Given this list of marker genes Jun, Sat1, Tbc1d4, Trim7, Ftl1 (NCBI Gene Id 14325), Evi2a, Dek, Slamf7, Adam23, Laptm5, Cxcl16, Mxd1, Csf2rb, H2az1, Mycbp2, Ucp2, H2bc4, Hspa1b, Chka, Hspa1a, Eno3, Cbfa2t3, Haus8 (NCBI Gene Id 76478), Btg2, here is a description of the gene set: Cytokines mediate cell-cell communication in the immune system and represent important therapeutic targets. A myriad of studies have highlighted their central role in immune function, yet we lack a global view of the cellular responses of each immune cell type to each cytokine. To address this gap, the authors created the Immune Dictionary, a compendium of single-cell transcriptomic profiles of more than 17 immune cell types in response to each of 86 cytokines (>1,400 cytokine-cell type combinations) in mouse lymph nodes in vivo. A cytokine-centric view of the dictionary revealed that most cytokines induce highly cell-type-specific responses. For example, the inflammatory cytokine interleukin-1β induces distinct gene programmes in almost every cell type. A cell-type-centric view of the dictionary identified more than 66 cytokine-driven cellular polarization states across immune cell types, including previously uncharacterized states such as an interleukin-18-induced polyfunctional natural killer cell state. Mouse Gene Set: CUI_LANGERHANS_TNFA_RESPONSE_DN from publication Cui A, Huang T, Li S, Ma A, Pérez JL, Sander C, Keskin DB, Wu CJ, Fraenkel E, Hacohen N (PMID 38057668) studied in species Mus musculus Genes negatively differentially expressed in cell type: Langerhans upon treatment with cytokine: TNF-α in mouse lymph nodes in vivo.